Given this list of marker genes PPOX, ALAD, CPOX, ALAS2, HMBS, FECH, UROS, ALAS1, UROD, here is a description of the gene set: studied in species Homo sapiens Human Gene Set: WP_HEMESYNTHESIS_DEFECTS_AND_PORPHYRIAS Hemesynthesis defects and porphyrias